Given this list of marker genes AGRP, MRAP, ASIP, MRAP2, POMC, here is a description of the gene set: Binding to a melanocortin receptor. species: Homo sapiens Human Gene Set: GOMF_MELANOCORTIN_RECEPTOR_BINDING